The following is a description of a gene set: Any process that modulates the frequency, rate or extent of ATP biosynthetic process. studied in species Mus musculus Mouse Gene Set: GOBP_REGULATION_OF_ATP_BIOSYNTHETIC_PROCESS, and this is the list of marker genes: Sphk2, Pid1, Bcl2l1, Atpsckmt, Myc, Ndufc2, Entpd1, Trem2, Eno1b, Eno1, Adcy10, Parp1, Il4, Vcp, Ppara, Stat3, Slc25a12, Prkn, Antkmt, Atp5if1, Tmsb4x, Map2k1, Dnajc30, Hnf1a